Given this list of marker genes UBB, UBC, JUN, NFKB1, UBE2V1, RPS6KA5, IRAK1, MAPKAPK2, MAP2K4, IRAK2, MAPK10, IKBKG, TNIP2, IL17RA, MEF2C, UBA52, IL17C, ELK1, PPP2CA, IL17F, ATF2, IL17A, MAP2K7, RPS27A, IL17RB, MAP2K1, BTRC, MAP2K6, CREB1, RPS6KA3, RPS6KA1, ATF1, MAPK9, CHUK, IL25, MAPK7, TRAF6, MAPKAPK3, NOD1, FOS, DUSP7, VRK3, NOD2, PPP2R1A, MAPK8, TAB2, CUL1, FBXW11, PPP2R5D, TAB3, TAB1, DUSP6, IL17RC, IL17RE, 8, MAP3K7, DUSP3, MEF2A, IKBKB, PPP2R1B, MAPK14, MAPK3, MAP2K3, SKP1, UBE2N, RIPK2, MAP3K8, PPP2CB, MAPK1 (NCBI Gene Id 5594), DUSP4, MAPK11, RPS6KA2, here is a description of the gene set: Reactome Pathway: Interleukin-17 signaling studied in species Homo sapiens Interleukin-17 (IL17) is a family of cytokines. IL17A, the founding member of the family is able to induce the production of other cytokines and chemokines, such as IL6, IL8, and granulocyte colony-stimulating factor (G-CSF) in a variety of cell types, including activated T-cells. It plays a pivotal role in host defenses in response to microbial infection and is involved in the pathogenesis of autoimmune diseases and allergic syndromes. IL17 activates several downstream signaling pathways including NFkB, MAPKs and C/EBPs, inducing the expression of antibacterial peptides, proinflammatory chemokines and cytokines and matrix metalloproteases (MMPs). IL17 can stabilize the mRNA of genes induced by TNF-alpha. IL17 signal transduction is mediated by the cytosolic adaptor molecule ACT1 (also known as CIKS).<br><br>The receptor for IL17D is unknown. part of: Signaling by Interleukins